Given this list of marker genes Tmsb4x, Rgs5, Ifi205, Adgre1 (adhesion G protein-coupled receptor E1), Spin1, Chchd10, Lcp1, L3mbtl3, Unc13d, Cadm4, Pcbd1, Clec7a, Eya4, Nuak1, Rgma, Smco4, Cpd, Celf2, Zhx3, Pkia (protein kinase inhibitor, alpha), Tyro3 (NCBI Gene Id 98916), Gmfg, Emilin1, Il2rg, Wipf1, L3hypdh, Matn2, Serpinb9, Bmp7, Lyz2, Mmp2, Mvp, Rpl14, Paics, Septin11, Lrrk1, Smtnl2, Taok3, Iars1, Hdgfl3, Prune2, Sipa1l1, Tmcc3, Klhl6, Enox1, Plxdc1 (plexin domain containing 1), Fbln5, Vegfd, Efs, Arhgef25, Hmga2, Ttc39a, Art3, Gxylt2, Kmt2c, Camkmt, Bmper, Ptpn12, Fstl1, Aldh1b1, Rbp1, Cacna1c, Snx24, Nid1, Ifi47, Carm1, Gli1, Rbms3, S100a16, Tmem178b, Cav2, Eva1b, Irag1, Gsto1, Rpl22, Cryab, Col12a1, Cdk14 (NCBI Gene Id 18647), Litaf, Rftn1, Gna14, Rpl22l1, Fgd1, Camk2n2, Tcim, Tcf4, Trim30a, Emp3, Lrrc4, Trp63, Smad5, Tgfbi, Otud1, Zfp423, Cst12, Tgm2, Gmpr, Ets1, Nhsl2, Nedd9, Ptpn1, Apbb2, C1qa, Sorcs2, Septin4, Doc2b, Nfix, Nfatc1, Lbh, Mcf2l, Gsn, Plscr2, Nav1, AI467606, Zfp36l1, Smim22, Angptl1, Sardh, Trpt1, Pltp, Ccl27a, Apoa1, Stox2, Dtd1, Laptm5, Zg16, Lrig1, Bag2, Fam110c, Cavin3, Hs6st2, Tmem204, Tnfaip8, Niban2, Lasp1, here is a description of the gene set: Genes up-regulated in ovarian tumors from mouse models for the BMP SMAD signaling (gonad specific double knockout of SMAD1 and SMAD5). The transforming growth factor beta (TGFbeta) family has critical roles in the regulation of fertility. In addition, the pathogenesis of some human cancers is attributed to misregulation of TGFbeta function and SMAD2 or SMAD4 mutations. There are limited mouse models for the BMP signaling SMADs (BR-SMADs) 1, 5, and 8 because of embryonic lethality and suspected genetic redundancy. Using tissue-specific ablation in mice, we deleted the BR-SMADs from somatic cells of ovaries and testes. Single conditional knockouts for Smad1 or Smad5 or mice homozygous null for Smad8 are viable and fertile. Female double Smad1 Smad5 and triple Smad1 Smad5 Smad8 conditional knockout mice become infertile and develop metastatic granulosa cell tumors. Male double Smad1 Smad5 conditional knockout mice are fertile but demonstrate metastatic testicular tumor development. Microarray analysis indicated significant alterations in expression of genes related to the TGFbeta pathway, as well as genes involved in infertility and extracellular matrix production. These data strongly implicate the BR-SMADs as part of a critical developmental pathway in ovaries and testis that, when disrupted, leads to malignant transformation. Mouse Gene Set: PANGAS_TUMOR_SUPPRESSION_BY_SMAD1_AND_SMAD5_UP studied in species Mus musculus from publication Pangas SA, Li X, Umans L, Zwijsen A, Huylebroeck D, Gutierrez C, Wang D, Martin JF, Jamin SP, Behringer RR, Robertson EJ, Matzuk MM (PMID 17967875)